The following is a description of a gene set: studied in species Homo sapiens Genes up-regulated in CD4 T cells versus follicular helper CD4 T cells. Analysis of in vivo antigen-specific (LCMV-specific, SMARTA TCR transgenic) follicular helper CD4 T cells (CXCR5high),versus non-follicular helper CD4 T cells (CXCR5low), eight days after viral infection. A paper including data analysis of these experiments has been accepted for publication (Robert J. Johnston et al. Bcl6 and Blimp-1 are reciprocal and antagonistic regulators of follicular helper CD4 T cell differentiation). Human Gene Set: GSE16697_CD4_TCELL_VS_TFH_CD4_TCELL_UP from publication Johnston RJ, Poholek AC, DiToro D, Yusuf I, Eto D, Barnett B, Dent AL, Craft J, Crotty S (PMID 19608860), and this is the list of marker genes: PRCP, CYBB (NCBI Gene Id 1536), MARCKS, TRIM7, CD81, REL, CSK, ALDH2, IKZF3, SLC46A3, PLCB3 (phospholipase C beta 3), HPSE, CHCHD4, TLNRD1, SPNS3, TLR2, TACSTD2, CYBA, TLR7, CAPG, DHDDS, PRKCB, SBK1, UBL3, KLHL14, PMF1, G6PC3, IDH3G, CTSA, ATP6AP1, RECQL5, TNFAIP8, HES5, CNRIP1, PHYKPL, ROGDI, ACTR3B, POU2F2, FES, PLEK, FKBP2, SLC16A6, DNAJC9, BMF, RDM1, RFX5, BCAR3 (BCAR3 adaptor protein, NSP family member), N4BP3, COMMD4, ACOX3, IL10RB, MYO1E, GNG2, STRADA, ADGRA2, SFXN5, IRAK3 (interleukin 1 receptor associated kinase 3), NFKB2, IL5RA, IQCB1, RPN1, BORCS7, RNH1, ZDHHC24, FCGRT, LIMD1, IFT172, SLC25A53, B3GNT8, HDAC9, ZBTB12, NUAK2, PLBD1, VCL, APOBEC3B, MGST1, TMEM131L, NFKBIE, EHD4, GPAT3, SERPINI1, MTPN, KCTD14, USP11, TUT4 (NCBI Gene Id 23318), TRIM35, BIN3 (bridging integrator 3), NUDCD1, BID, APOE, IRGQ, ABHD17A, KDM2B, ATP2A3, CALR, IFT22, FUT11, MAP4K1, COASY, ATP6V0D1, MAPRE2, MID1IP1, PLEKHG3, SH2B3, ASAH1, ANXA1, ARHGAP17, TFEB, PPM1E, SERINC3, RASGEF1B, ARHGAP21 (Rho GTPase activating protein 21), GRN, CUTC, ARHGAP11A, UBLCP1, CNR2, ABCB10, PGLS, SNRNP35 (small nuclear ribonucleoprotein U11/U12 subunit 35), RELB, RAB30, TMEM168, DENND4A, KDM2A, TCEANC, LAMP2, IFT70A, GCNT1, ASNSD1, KCNG1, PTGR2, MYO18A, PIKFYVE, NAT1, CERK, GPD1L, ATG16L2, CD40, SLC16A7, PACRGL, LTA, NUBP1, CEP89, C19orf38, TRAPPC5, BFSP2, GBP4, ICAM1, ZNF821, ADAM9, HLA-G, GCOM1, EHD1, DTNBP1, HMOX2, SLC66A2, EFCAB2, CAMK2D, CLIC4, CENPS, ATP13A2, GM2A, PLP2, ELL2, SZRD1, MYADM (myeloid associated differentiation marker), ZNF600, GRB2, NCKIPSD, NOXRED1, TMEM263, PRKCD, RNF130, ABI3, LRRK2, NAP1L1, RGS18, TSGA10, PLXND1, SEMA4B, UMAD1, ERP29, RNF181, MACIR, ARHGAP26, RASGRP3, NMRAL1, IVD, C6orf89, TDRD7, BLOC1S5 (NCBI Gene Id 63915), MAGOHB, PDE7A, MAPKAPK2, LANCL2, HVCN1, UNC119, CHD9, PARVG